Given this list of marker genes PLAU, RBL1, APAF1, RB1, YY1, E2F2, UXT, HBP1, CDKN1A, RBBP4, TFDP1, SIRT1, KAT2A, TOPBP1, E2F7, E2F1, EP300 (E1A binding protein p300), TFE3, CDK2, E2F5, RRM1, HDAC1, CES1, MYC, CDKN2A, CDKN2C, CREBBP, CCNE2, CES4A, TRIM28, CCNA2, CCNE1, ATM, CES3, SP1, SERPINE1, E2F4, MCM3, CDKN1B, TYMS, CCND3 (cyclin D3), SMARCA2, TK1, TFDP2, CES5A, WASF1, BRCA1, MCL1, TRRAP, MYBL2, CDK1, RBBP8, RRM2, CDC25A, CASP7, XRCC1, RANBP1, RBL2, ORC1, CES2, SULT2A1, DHFR, E2F3, PRMT5, CDC6 (NCBI Gene Id 990), HIC1, CBX5, E2F6, POLA1, KAT2B, CEBPA, TP73, RYBP, here is a description of the gene set: E2F transcription factor network Human Gene Set: PID_E2F_PATHWAY species: Homo sapiens from publication Schaefer CF, Anthony K, Krupa S, Buchoff J, Day M, Hannay T, Buetow KH (PMID 18832364)